The following is a description of a gene set: Genes up-regulated in gamma delta T cells stimulated by phorbol myristate acetate and ionomycin: Vd1 versus Vd2. Human Gene Set: GSE3720_VD1_VS_VD2_GAMMADELTA_TCELL_WITH_PMA_STIM_UP from publication Kress E, Hedges JF, Jutila MA (PMID 16423401) The two major human gd T cell subsets, Vd1 and Vd2, display differences in tissue tropism and agonist responses, but we have little insight into global differences that may exist at the gene expression level. This is due to the small numbers of these cells that can be obtained from healthy donors, which limit comprehensive, comparative gene expression analyses. We established a culture method that expands Vd1 and Vd2 cells from the same PBL preparation to levels sufficient for sorting and microarray analysis. Although the subsets were expanded identically (anti-TCR mAb, plus IL-15), 392 and genes were identified, which were differentially expressed in the two subsets, from two donors, respectively. Approximately genes changed in both subsets following PMA/ionomycin treatment; about 50% of these genes were subset-specific. Both subsets responded to a crude LPS preparation, but only 6% of the responsive genes were the same. The differentially expressed genes were consistent with Vd2 cells being more inflammatory and Vd1 cells having more of a regulatory phenotype. Both subsets expressed transcripts encoding an array of innate and NK cell receptors, supporting the relationship of gd T cells to the innate immune system. Our results show that circulating Vd1 and Vd2 subsets in humans have considerable, inherent differences in gene expression following treatment with non-TCR agonists, supporting unique functional roles for these cells in vivo. studied in species Homo sapiens, and this is the list of marker genes: C16orf92, PROC, DYNLT3, ZNF512B, ENPP2, SYPL1, LCLAT1, LINC01973, BRI3BP, TIMM8B, IFNAR2, USP11, MYO7A, UBE2L3, KIF1B, FYN, HHAT, RACK1, ADIPOR2, ST3GAL2, NSRP1, TCF12, DENND2D, SLC26A11, ZMYND8, MAPK8, FHL3, ANKRD46, SH3GL3 (NCBI Gene Id 6457), SMOX, LUC7L3, GAD1, KIF3A, GAR1, RFX8, ASF1A, SUSD6, RPGR, CFAP418, CHML, C3, CDK13, MSH6, PHLPP1, FAM162A, MRPS25, MIGA1, RNF170, NHP2, GDPD5, PPIG, SNAPC1, HSDL1, MCCC2, PDLIM1, KRCC1, LIMS4, CST7, ADARB1, RAB11A, STING1, FXR1, MGST2, TPD52, REXO2, KIF7, NEK4, SLC25A36, ACSL3, TSPAN3, UBE2S, ODC1 (NCBI Gene Id 4953), NUP43, TMA16, PRNP, SQOR, ARID4A, DDIT4 (NCBI Gene Id 54541), PPCS, PADI4, LAMP2 (lysosomal associated membrane protein 2), NME1, SGPP2, TMEM131, EGR3, BEND3, NAA16, IFT74, ZEB1, LAP3, CD300LB, SLC25A3, AGT, RPA1, CLIP4, METAP1D, ZNF518B (zinc finger protein 518B), MLH3, BCOR (BCL6 corepressor), CHORDC1, TULP1, PGAM1, PEX1, MDN1, ZNF667, GALNT18, GSKIP, PHB2, STAT5A, SPMIP4, NSMF, AP3B1, PIPOX, IKBKE, TTC3, KANSL2, STIM2, ATP6V0E2, TMED3, ZFR2, SLC25A4, RELB, STK4, WSB1, IMPDH2, SLC2A6, MYO1C, HACD3 (NCBI Gene Id 95112), MTAP, DTD1, HPCAL1, SRM, HS1BP3, TJP2, EXOSC5, TGFB3, TDRP, CACYBP, FAM222B, BAIAP2L1, GNAQ, MYH3, PLEKHG2, FASN, PLXNA3, SLC9B2, TBC1D4, SEC14L1, IWS1, ITK, CDK17, HIPK3, SCCPDH, ARHGAP39, GPM6B (glycoprotein M6B), CRPPA, ADAT2, CISD1, STK38L, NOP2, SSB, ITGB3BP (NCBI Gene Id 23421), LY6D, FRMD4A, ISOC1, SNED1, WDR12, DCK, CREG2, MAGED1, TRIM8, GPRASP3, NRIP1, ERLIN1, PCBP3, C1QBP, ZMYM3, HLA-DMB, RASL12, ACAT1, TOR1AIP2, S1PR2, IL13, PDK1, CD83, ACOT12, CAMK2D, GAB2, MBOAT7, SIX5, GLRB, FAM83G, ARMCX2, QRICH1, DRAM1, LIPA, NFKBIA, CORO2B, CPLANE1, DYNLRB1